The following is a description of a gene set: studied in species Homo sapiens Inflammation of the tongue. Glossitis Human Gene Set: HP_GLOSSITIS, and this is the list of marker genes: PTPN22, HLA-DRB1, P4HA2, SLC6A19, CUBN, LMBRD1, CLTRN, AMN, SLC46A1, SLC39A4, MMACHC, HLA-B